The following is a description of a gene set: Genes down-regulated in T cells stimulated by IL2 for 6h: STAT5 double knock-in versus wildtype. Human Gene Set: GSE36888_STAT5_AB_KNOCKIN_VS_WT_TCELL_IL2_TREATED_6H_DN from publication Lin JX, Li P, Liu D, Jin HT, He J, Ata Ur Rasheed M, Rochman Y, Wang L, Cui K, Liu C, Kelsall BL, Ahmed R, Leonard WJ (PMID 22520852) species: Homo sapiens Cytokine-activated STAT proteins dimerize and bind to high-affinity motifs, and N-terminal domain-mediated oligomerization of dimers allows tetramer formation and binding to low-affinity tandem motifs, but the functions of dimers versus tetramers are unknown. We generated Stat5a and Stat5b double knock-in (DKI) N-domain mutant mice that form dimers but not tetramers, identified cytokine-regulated genes whose expression required STAT5 tetramers, and defined consensus motifs for dimers versus tetramers. Whereas Stat5- deficient mice exhibited perinatal lethality, DKI mice were viable, indicating that STAT5 dimers were sufficient for survival. Nevertheless, STAT5 DKI mice had fewer CD4+CD25+ T cells, NK cells, and CD8+ T cells, with impaired cytokine-induced proliferation and homeostatic proliferation of CD8+ T cells. DKI CD8+ T cell proliferation following viral infection was diminished and DKI Treg cells did not efficiently control colitis. Thus, tetramerization of STAT5 is dispensable for survival but is critical for cytokine responses and normal immune function., and this is the list of marker genes: FAM111A, TRIM44, CENPA, XPR1, LRRC59, NIPA2, H2AX, DEPDC1B, CDC14A, KLHDC2, SSBP3, HJURP, CCP110, PLIN2, MYCN, NR2F6, GPD2, ARL5A, PLK4 (polo like kinase 4), ZDHHC16, TLE4, TIMM22, PSAT1, FCER1G, LBR, UGCG, SLC25A46, ARRB1, EMC1, ZNF326, IPMK, MSH6, PTCH1, SMC4, SKP2, GLIS2, MORF4L2, SGO2 (NCBI Gene Id 151246), ZNF22, SASS6, TRIM36, GALE, MAPRE1, TAF5, EPB41L2, ARAP3, KCTD12, TGFBR1, TIRAP, CEP104, H1-2, NCK2, RHOB, TEDC2, INPP4A, HAUS3, ADGRB2, SMURF2, GLCCI1, COPS3, DGCR8, KIF2C, TNFRSF1A, G0S2, ANP32E, PLSCR3, SLC30A4, PDCD4, DUSP1 (dual specificity phosphatase 1), OSBPL8, ATP5F1A, DYNLT1, CEMIP2, OPA1, GPC1, ASF1A, TYROBP, TMEM223, TBC1D31, CENPJ, XPNPEP1, ZNF473, MAGOHB, GRINA, MARVELD1, RAP1GDS1, CCDC28B, SEC23A, SLBP, GIMAP4, PEPD, CENPI, LRRK1, ARSB, UMAD1, CDC27, CD151, MMS22L, DCXR, SMUG1, EME1, NRARP, POLE2, WDR5, PRPF3, STYK1, H2BC3, FGL2, ZNF598, CENPN, CALU, KIF11, MXD4, C2orf69, MYO6, SRP68, TSPAN4, LRRC57, LAMTOR4, ATXN7L3B, SPTBN1, AURKA, DAB2IP, ADSS1, GZMA, TPX2, CDCA4, SLC41A2, KLRD1, ZNF318, TCF4, CDC42EP1, ZFAND5, H2BC13, P3H4 (prolyl 3-hydroxylase family member 4 (inactive)), SOAT2, DNMT3A, PRKCB, PTTG1IP, BCLAF3, FRMD4A, WDR6, IKZF2, GAB2, ALMS1, GGA3, CNPY4, DUS1L, RNF26, ATL2 (atlastin GTPase 2), EHD4 (EH domain containing 4), SERPINB9, ENKD1, CRYBG2, ARHGAP19, MKLN1, SOCS5, KLF10, DPAGT1, MMGT1, IRGQ, MGAT5, PPIH, GZMB, RFX3, RIPK3, CD244, TMEM18, STING1, NEDD4, TESC, PIAS3, CTNNB1, PDXDC1, FUCA2, DNM1L, TPP1, FKBP10, MTOR, RFX5, INSL6, WDR31, MNS1, CD160, ASB7, METRN, RAB43, ING1, HASPIN, GPSM2, CELA1, CHAC2, PTGER4, DIAPH3, SMC5, ARHGAP11A, CYP51A1, DNMT1, PRIM2, LRRC40 (NCBI Gene Id 55631)